The following is a description of a gene set: species: Homo sapiens Human Gene Set: GOBP_GLUTAMATE_RECEPTOR_SIGNALING_PATHWAY The series of molecular signals initiated by the binding of glutamate to its receptor on the surface of a target cell, and ending with the regulation of a downstream cellular process, e.g. transcription., and this is the list of marker genes: HOMER1, GRM4 (glutamate metabotropic receptor 4), HOMER2, GNAQ, IFNG, CCL2, CAPN1, GRIA3, GRIA1, GRM5, FMR1, SHANK3, GRID2, GRM7, GRIA2, IFNGR2, NLGN3, GRIN3A, NLGN1, GRM6, NRXN1, APP, PLCB1, GRIN2A, GRM2, C14orf28, HOMER3, CPEB4, FYN, CDK5R1, GRM1, MEF2C, TRPM1, SLC1A1, SSTR1, NECAB2, KCNB1, GRIK5, GRIK1, SHANK1, PTK2B, GRIN2B, GRM3, GRIN3B, GRIN1, GRM8, GRID1, DLG4, FRRS1L, GRIK4, GRIK3, ADRB2, CLN3 (NCBI Gene Id 1201), GRIN2C, GRIK2, EPHB2, GRIA4, NCSTN, GRIN2D (glutamate ionotropic receptor NMDA type subunit 2D), CX3CL1, CCR2 (C-C motif chemokine receptor 2), PRNP